Given this list of marker genes Spi1, Ywhab, Insig1, Usp38 (NCBI Gene Id 74841), Nck1, Ywhae, Sdcbp, Nfkb1, Tarbp2, Upf3a (NCBI Gene Id 75230), Sri, Sfn, Insig2, Tmsb4x, Smo, Tacc3, Impact, Sec14l1, Laptm5, Ywhag, Mdfi, Pfn1, Flna, Sesn2, Castor1, Ywhaz, Lrrc15, Kifbp, Sufu, Tmsb15b2, Stat3, Cdkn1a, Ddx56, Tmc8, Tmsb15l, Ctnnd1, Smad6, Nfkbia, Sqstm1, Dzip1, here is a description of the gene set: Mouse Gene Set: GOMF_PROTEIN_SEQUESTERING_ACTIVITY studied in species Mus musculus Binding to a protein to prevent it from interacting with other partners or to inhibit its localization to the area of the cell or complex where it is active.